The following is a description of a gene set: We identified Pparg as a major orchestrator of the phenotype of adipose-tissue resident regulatory T cells (VAT Tregs). To establish the role of Pparg in shaping the VAT Tregs gene profile and cell dynamics, Tregs from lymph nodes and visceral adipose tissue of mice sufficient and deficient of Pparg expression in Tregs were double sorted for microarray analysis. Genes down-regulated in visceral adipose tissue from aged PPARG knockout mice: T reg versus T conv. from publication Cipolletta D, Feuerer M, Li A, Kamei N, Lee J, Shoelson SE, Benoist C, Mathis D (PMID 22722857) Human Gene Set: GSE37532_TREG_VS_TCONV_PPARG_KO_CD4_TCELL_FROM_VISCERAL_ADIPOSE_TISSUE_DN species: Homo sapiens, and this is the list of marker genes: GAL3ST2, AKTIP, STK17B, EAF2, LGR5, BTLA, PDE2A, RNF145, CD53, HSPA2, TMEM30A, SPATA6, ARHGAP6, IDH1, BRD9, C8orf58, DUBR, B3GNT5, HEXB, ATAD1, CCNL2 (cyclin L2), XIAP, CACNB4, RFX5, SH3GLB1, DNAH8, GGA2, GSN, DDX17, GCNT3, PARP8 (poly(ADP-ribose) polymerase family member 8), RRM2B, AP3M2, SLC28A2, TLR1, YPEL5, ADCY7, CCDC28B, RCHY1, RABGAP1L, TRAM1, BAIAP2L1, GNB4, H2BC13, LMBRD1, FAM221A, ABCA1, FRY, RGS14, LRATD2, CLK4, TSPYL4, ATOSA, PDZD2, ESYT3, MINDY2, MBD2, PIK3CG, SLA, CLTA, RGS2 (NCBI Gene Id 5997), CCNG2, SCARB2, HPS5, CASP9, CREBRF, PLEKHA2, ADGB, CR2, LMO2, PGAP1, SYPL1, BTG1 (BTG anti-proliferation factor 1), DCAF12, SEC16B, RASA3, CYTIP, BANK1, SLC46A3, ICOSLG, FOXJ2, TCEANC2, SLC41A2, HP1BP3, BCL6, IRF2, ERO1B, GDI1, CEBPG, CPE, SELENOP, HLA-DOB, GPR171, UBE2H, TGFA, BRWD1, ZUP1, EIF2AK3, C17orf58, RBM5, PRR13, TMEM181, ETS1, RALGPS1, CTSO, STT3B, GABBR1, OSBPL9, ADD3, CHKB, GIMAP8, NHERF4, CARD6, KLHL42, PTGR1, RALGPS2, KRIT1, FAM13B, SLC30A5, HPSE, MBD4, PIPOX, PIGV, CRLF3, IFIT1, PRIMPOL, APOBEC1, IRF9, C5orf34, DNAAF9, TP53INP1, TTPAL, AICDA, GTPBP2, SUSD1, SHARPIN, TP53INP2 (NCBI Gene Id 58476), KLF6, DAZAP2, TMEM71, SERINC5, GCNT1, SCN11A, HERC3, EPC1, SATB1, TXNDC16, MYLIP, GRM5, CCDC186, ARRDC3, ETNK1, POLI, TRIO, TKTL1, LINC00511, MARCHF1, UCKL1, PDE7A, KIAA1191, LASP1, TPD52 (NCBI Gene Id 7163), ZBTB4, AP1S2, CDS2, SLC12A6, MSN, BACH2, MKRN1, SAT1, ANKRD44, GZF1, OTUD1, RIGI (NCBI Gene Id 23586), TRAM2, CBLB, PNRC1, ATP8A1, ZNF217, KLHL24, LPIN2, KBTBD7, KRT222, CTCF, MED13L, INTS6L, PCMTD1, SEPTIN6, LATS2, MON1B, DUSP22, FAS, CWC27, DHX40, ACSS1, ZC3H7A (zinc finger CCCH-type containing 7A), MS4A1, CENPT, RELN, CLK1